The following is a description of a gene set: The process in which nerve cells are generated in the forebrain. This includes the production of neuroblasts from and their differentiation into neurons. Human Gene Set: GOBP_FOREBRAIN_GENERATION_OF_NEURONS species: Homo sapiens, and this is the list of marker genes: RAPGEF2, WNT3A, UBB, METTL14, SCYL2, SLC4A10, DCLK2, NR2E1, PROX1, PLXNA1, ID4, NHLH2, ELAVL4, ASPM, OPHN1, NRP2, BCL11B, HPRT1, GSX2, DLX5, ZNF335, UNCX, ROBO2, TOX, DCT, ARX, FGFR1, CNTN2, ZSWIM6, DLX1, PAX6 (NCBI Gene Id 5080), FOXG1, LEF1, GLI3, DRD1, SLIT2, NDNF, RAC1, LHX8, ZMIZ1, FEZF2, ASCL1, GBX2, DRD2, DISC1, SLIT1, SIN3A, EMX1, EOMES, ZDHHC16, ERBB4, RHOA, PEX5 (NCBI Gene Id 5830), LHX6, INHBA, OTP, METTL3 (methyltransferase 3, N6-adenosine-methyltransferase complex catalytic subunit), GATA2, NKX2-1, WNT5A, SEMA3E, ATP7A, FGFR2, ROBO1, CSF1R, SECISBP2, SOX1, CHD5, LHX5, DLX2, B2M, RAC3, SALL1, HES1 (hes family bHLH transcription factor 1), NRP1, UQCRQ, FGF8, OGDH, C21orf91, PAFAH1B1, TFAP2C, TBR1, ATF5, SHANK3, SLIT3, PLXNA3, PSEN1